Given this list of marker genes Sox9, Wnt7b, Hoxa5, Rspo2, Lrp6, Srf, Rarg, Rara, here is a description of the gene set: species: Mus musculus Mouse Gene Set: GOBP_TRACHEA_CARTILAGE_DEVELOPMENT The process whose specific outcome is the progression of the tracheal cartilage over time, from its formation to the mature structure. Cartilage is a connective tissue dominated by extracellular matrix containing collagen type II and large amounts of proteoglycan, particularly chondroitin sulfate.